The following is a description of a gene set: Mouse Gene Set: GOBP_RESPONSE_TO_TESTOSTERONE species: Mus musculus Any process that results in a change in state or activity of a cell or an organism (in terms of movement, secretion, enzyme production, gene expression, etc.) as a result of a testosterone stimulus., and this is the list of marker genes: Kcnj11, Ar, Epo, Hoxa11, Rnf4, Gba1, Calr, Tbxa2r, Cdk4, Rps6kb1, Hsf1, Slc39a9, Mup1, Elk1, Spp1, Edn1, Hoxa13, Mstn, Slco1a1 (solute carrier organic anion transporter family, member 1a1), Uts2, Defb1, Cacna1b, Avp, Hoxa10, Hoxb13 (homeobox B13), Cad, Gpi1, Aard, Cbl, Msn, Mup11, Hoxa9, Tspo, Adh1, Car9, Psph, Hmgcs2, Rock2, Hoxd13, Nkx3-1, Akr1c18, Esr2, Pln, Rwdd1, Nqo1, Srd5a2, Csnk2a1, Cflar, Sirt1